Given this list of marker genes ALDOB, RETREG1, EPAS1, ELP1, WNK1, SDHAF2, SDHB, NF1, DLST, TMEM127, KIF1A, MDH2, KIF1B, VHL, HNF1A, DNMT3A, MAX, SDHD, UCP2 (uncoupling protein 2), SDHA, SDHC, SLC25A11, SCN9A, KCNJ11, RET, ABCC8 (NCBI Gene Id 6833), FH, here is a description of the gene set: Episodic hyperhidrosis Human Gene Set: HP_EPISODIC_HYPERHIDROSIS Intermittent episodes of abnormally increased perspiration. species: Homo sapiens